Given this list of marker genes MYRIP, TBC1D10A, GCC2, RAB27B, SYTL2, RAB27A, SYTL5, RPH3A, MADD, RPH3AL, SYTL1, EXPH5, SYTL4, MLPH, UNC13D, SYTL3, here is a description of the gene set: Deregulation of Rab and Rab effector genes in bladder cancer species: Homo sapiens Human Gene Set: WP_DEREGULATION_OF_RAB_AND_RAB_EFFECTOR_GENES_IN_BLADDER_CANCER